Given this list of marker genes CCL5 (C-C motif chemokine ligand 5), ROBO1, PADI2, RNF113A, SLIT3, SH2B3, MIR101-1, MIR20A, SLIT2, here is a description of the gene set: Human Gene Set: GOBP_NEGATIVE_REGULATION_OF_CHEMOKINE_MEDIATED_SIGNALING_PATHWAY Any process that decreases the rate, frequency or extent of a chemokine-mediated signaling pathway. species: Homo sapiens